The following is a description of a gene set: studied in species Homo sapiens Genes predicted to be targets of miRBase v22 microRNA hsa-miR-5002-3p in miRDB v6.0 with MirTarget v4 prediction scores > 80 (high confidence targets). from publication Chen Y, Wang X (PMID 31504780) Human Gene Set: MIR5002_3P, and this is the list of marker genes: ZBTB5, C1GALT1, THRSP, UPF2, AWAT1, SLC25A36, THAP5, PPP3CA, RMND5A, MACO1, WFDC3, EBPL, CSTF2, GDAP2, MGMT, PKN2, SETBP1, SAMD8, TSC22D1, NLGN4X, PON1, ARID4A, MRPL58, CEP20, CAB39, MLEC, KPNB1, MARCHF5, RBM41, CACNB4, EHMT1, PIP4K2B, EFCAB13, NPAT, DNALI1, CYP21A2, SIX3, CYRIA, TYW5, TRPM7, ABCA5, PPP1R12A, ZIC3, CLINT1, PATZ1, NFKBIZ, CRMP1, DOCK3, MAT2B (methionine adenosyltransferase 2 non-catalytic beta subunit), MSTN, CAV1 (caveolin 1)